The following is a description of a gene set: species: Homo sapiens Human Gene Set: HP_DOWN_SLOPING_SHOULDERS Down-sloping shoulders Low set, steeply sloping shoulders., and this is the list of marker genes: EYA1, LIMK1, GABRA3, BUD23, PTCH1, ATP7A, PPP1R15B, EIF4H (eukaryotic translation initiation factor 4H), CHD7, SPRTN, TMEM270, FKBP6, ELN, BAZ1B, BCOR, LMNA, METTL27, GTF2IRD2, GTF2IRD1, GTF2I, OTUD6B, MLXIPL (MLX interacting protein like), PIEZO2, NCF1, STX1A, RFC2, EFNB1, TRPV4, TBX5, CHRNG, CUL4B, RUNX2, CBFB, LMBRD2, CLIP2, DNAJC30, IRX5 (iroquois homeobox 5), FIG4, TRMT10A, NAA10, VPS37D, BRD4, TBL2, PAX1